Given this list of marker genes SPCS3, SEC11A, SEC11B, SEC11C, SPCS2, SPCS1, here is a description of the gene set: Human Gene Set: GOCC_SIGNAL_PEPTIDASE_COMPLEX A protein complex that is located in the endoplasmic reticulum membrane and cleaves the signal sequence from precursor proteins following their transport out of the cytoplasmic space. studied in species Homo sapiens